Given this list of marker genes BCL2L13, PFKM, PGK2, HK2, ENO1, PFKP, PFKL, GPI, GCK, PGK1, FOXK2, TPI1, TIGAR, HK1, LDHA, PFKFB2, TKTL1, ENO3, PGAM2, TP53, HK3, BAD, PGAM1, ADCY10, ACTN3, FOXK1, LRP5, ENO2, MIR210, PKM, here is a description of the gene set: The chemical reactions and pathways resulting in the breakdown of glucose, the aldohexose gluco-hexose. Human Gene Set: GOBP_GLUCOSE_CATABOLIC_PROCESS species: Homo sapiens